The following is a description of a gene set: A fold of skin starting above the medial aspect of the upper eyelid and arching downward to cover, pass in front of and lateral to the medial canthus. Human Gene Set: HP_EPICANTHUS Epicanthus species: Homo sapiens, and this is the list of marker genes: ACOX1, MED12, ASXL3, TBX2, RYR1, UBE3A, FAT4, SCAF4, FAM149B1, ANGPT2, RALA, COL11A1, UGDH, KCNH1, GNE, SLC25A24, SYT1, RSPRY1, VDR, TBX22, GJA1, TMEM216, STX1A, VPS51, ASXL2, CHRNG, BRCA2, H4C5, HIC1, CERT1, GABRD, IFT80, IFT140, DPH2, HBA2, RPS6KA3, SOX4, ADNP, FOXL2, PPP1CB, FIG4, PRDM13, PEX1, CHD8, DDB1, RAB3GAP2, FLNA, COL9A1, TSR2, WAC, ALDOA, ZMIZ1, PEX6, SLC39A7, KMT2B, EXT2, FGFR2, YWHAE, SON, TRMT10A, TWIST1, RFX7, COLEC10, XRCC4, CHD7, CHRNA1, GUSB, ABCC9, PIGL, GFRA1, TBX4, PEX13, MINPP1, ZFX, PEX16, DDR2, CCDC88A, SLC17A5, ALX1, KIAA0586, FLI1, TCF3, RPL26, CASZ1 (castor zinc finger 1), BCL11A, BAZ1B, INPP5E, B9D2, PTCH2, PIEZO1, NXN, NBAS, PRPS1, MICU1, KMT5B, PREPL, CNTNAP1, BPTF, MYCN, ALG12, TONSL, KDM6A, EP300, PNPLA6, KCNAB2, ZNF462, TBL2, DLK1, DYNC2I1, SEPTIN9, FIBP, DPF2, ROR2, XRCC2, DMXL2, ATN1, TOPORS, MAN1B1, RAP1B, COG6, MYMK, ZMYM2, RPL8, RIN2, KRAS, SLX4, GPC4, UFD1, CSF1R, RAB23, IGHM, ASXL1, SMC3, GATAD2B (GATA zinc finger domain containing 2B), REV3L, DNMT3A, CDC42BPB, NOTCH2, FANCE, IGLL1, BMP4, CAMK2A, ZBTB20, TPRKB, PMM2, RPL11, RERE, BCL11B, POLR1A, DHCR7, POU3F3, TLK2, GPC3, AGO1, KMT2D, FGF20, RPL27, ERCC4, BICRA, FGFRL1, ZNF469 (NCBI Gene Id 84627), MEGF8, H3-3A, FANCI, BUB1B, PEX5, ALDH6A1, ERCC2, MAB21L2, EED, GJA8, YARS1, STAG2, LIG4, CPLX1 (NCBI Gene Id 10815), RPL35A, FANCB, SRRM2, KCTD1, TRIP12, PUS7, PPP2R3C, SOX5, HUWE1, SIAH1, MAP1B (microtubule associated protein 1B), MYMX, PRKAR1A, WBP4, KAT6B, COL1A1, PIGG, ZBTB24, MAPK1, SRCAP, HRAS, SC5D, DPH1, PEX14, FANCL, HS2ST1, CD79B, PPP1R21, CTBP1, COA3, WWOX, KIF11, HEATR3, PIEZO2 (piezo type mechanosensitive ion channel component 2), PRKCZ, IFT122, BUD23, LRRC8A, PEX19, RIT1, PIGO, UBE4B, B4GALT7, CPLANE1, NDST1, KIF7, DVL3 (dishevelled segment polarity protein 3), PCDHGC4, RYR3, MASP1, BUB1, PAFAH1B1, XYLT1, PPP2CA, SNX14, TOE1, NCF1, MADD, HECW2, NELFA, TBCK, RMRP, CCBE1, BUB3, HIRA, RPS29, ATP6V1B2, CCDC47, ADAT3, NSD2, RNF113A, PIK3CA, ZNF292, RAF1, RPS23, FKBP14, RECQL4, INTS11, UQCC2, CD79A, EEF1A2, CREBBP, SOX9, FZD2, PRDM16, COL18A1, DHCR24, FBXO11, INTS1, HELLS, CBL, CARS1, SUFU, MYH3, BMPER, IFT52, FGD1, DHX30, BRAF, SPART, CHRNA7, GTF2IRD2, DNAJC30, RPL5, FOXP2, SNRPB (small nuclear ribonucleoprotein polypeptides B and B1), GTF2H5, RAD51C, ARID1B, ZNHIT3, EPG5, PIK3C2A, PDE6D, ZBTB18, PTCH1, FBXL4, MARS1, ZNF407, ALX4, METTL27, HK1, EBF3, ALX3, RPS28, SKI, PEX3, PIGW, SCNM1, CHAMP1, COL3A1, JARID2, UGP2, RPS26, FKBP6, KMT2A, DHX9, TMEM53, FANCD2, ZEB2, WDR19, RAD51, CNOT1, FLT4, UBE2T, KDM6B, EIF4A2, RPL15 (ribosomal protein L15), AP1G1, TRIP13, SEC24C, RPS19, ARVCF, CHRND, TMEM237, EZH2, EDEM3 (NCBI Gene Id 87240), LUZP1, NAA20, DPH5, SLC35A2, GATA2, MMP23B, NAA10, NCDN, RTL1, ADAMTS3, SEMA5A, VPS53, ERI1 (exoribonuclease 1), TEFM, THOC6, PEX10, NOTCH3, DYNC2I2, CNTNAP2, PIGV, HOXB1, ABCA5, WDR4, SUPT16H, PEX11B, BRAT1, NRAS, PDPN, NANS (N-acetylneuraminate synthase), UFC1, ACTG1, PGM2L1, SMARCA2, AUTS2, CLIP2 (NCBI Gene Id 84805), HBA1, GDF11, RHOBTB2, SMPD4, SPEN, RPS10, NAA80, LETM1, PAK2, AARS1, LONP1, TCF20, WDR73, ATP6V0A2, PGAP3, PLOD1, CASK, PEX2, MAP3K7, PRORP, PEX26, PPP1R12A, FANCC, ANTXR1, NUP188, NR2F1, ACTB, MACF1, GJC2, ANK1, ARID2, CHD5, FOXG1, AMER1, COMT, CSNK2A1, RNU4-2, SVBP, ATP9A, COQ4, PHF21A, MPLKIP, GPT2, VPS33A, VPS37D, DDX6, TBX1, COG8, RPS17, DNAJC21, GJA5, FANCA, KIAA0753, TRAPPC9, NF1 (NCBI Gene Id 646021), HNRNPH2, GLI2, AFF2, TFE3, GTF2E2, PLXND1, COL5A2, PRKAR1B, ALG2, FDFT1, UNC80, GREB1L, ITGA8, SMC5, MAPRE2, EFTUD2, NSDHL, DYNC2H1, WNT5A, TMEM270, IFT43, PQBP1, FILIP1, KAT8, MLXIPL (NCBI Gene Id 51085), TRIO, BCAS3, RPL35, MTSS2, MRPL12, SETD1A, THUMPD1, EIF5A, HNRNPU (heterogeneous nuclear ribonucleoprotein U), OSGEP, PTEN, DNMT3B, PIGN, TRRAP, WDR37, NONO, RFC2, ADAMTSL2, CDK10, JMJD1C, ADA2, PIGY, FGF10, TWIST2, SRY, MKS1, PALB2, SPOP, BMP2, GTF2I, FGFR1, CLCN3, ASPM, CHD3, HIBCH, BLNK, DEAF1, FERRY3, CDCA7, MAP2K2, PTPN11, SIX2, NSUN2, DLX4, TARS1, WNT9B, SHANK3, COL5A1, SLC3A1, NFIX, SIN3A, GTF2IRD1, FANCF, QARS1, CDK13, RPL31, HSD17B4, UBAP2L, GATA4, LIMK1, FOCAD, RREB1, COLEC11, MAN2B1, BRIP1, CSPP1, MAD2L2, DVL1, RPL10, PGAP2, SPRED2, HSPG2, EIF4H, WNK3 (WNK lysine deficient protein kinase 3), DOCK3, PIK3R1, TASP1, MSL3, MED13L, POGZ, CD96, PUF60, SOX18, UHRF1, WDR35, PUM1, UBE3B, FGFR3 (NCBI Gene Id 55546), SHOC2, PDHX, TUBB, ZNF148, CHD4, MPC1, AHDC1, SPI1, NALCN (sodium leak channel, non-selective), GNPTAB, RET, KANSL1, DIS3L2, SHROOM4, CTNND2, PURA (NCBI Gene Id 5813), FANCG, MEG3, TMCO1 (transmembrane and coiled-coil domains 1), LMBRD1, PEX12, POLRMT, KCNJ8, ADAMTS2, RPS15A, PIGU, ALG9, LZTR1, GATA1, RPS20, ELN, MED25, KAT6A, RIC1, RPL9, EXOSC9, PHIP, BRCA1, MAP2K1, ERCC3, DHX16, WNT7A, CEP57, RPS7, ALG3, CLCN7, PAH, PBX1, TBC1D24, ATRX, RFWD3, PDE4D, AGO2, SCN4A, RPL18, GP1BB, DCHS1, GLIS3 (NCBI Gene Id 648268), TMEM147, SLC26A2, DYNC2LI1, CUL4B, TRAF7, SEMA3E, GPC6, WT1, SALL4, TUBB3, ACBD6, PRMT7, FANCM, NBN, COL1A2 (NCBI Gene Id 1278), PPP1R15B, TAF1, SOS1, RPS27, RB1, AP3B1, PAX3, OFD1 (OFD1 centriole and centriolar satellite protein), TMEM231, RPS24, SPRED1, MECP2, TCTN3, DDX11, CTCF, AHI1